The following is a description of a gene set: studied in species Homo sapiens Generation of the female gamete; specialised haploid cells produced by meiosis and along with a male gamete takes part in sexual reproduction. Human Gene Set: GOBP_FEMALE_GAMETE_GENERATION, and this is the list of marker genes: MEIOB, PAQR8, EDNRA, CCNB2, LSM14B (NCBI Gene Id 51153), NANOS1, ZFY, SPIRE1, M1AP, PGR (NCBI Gene Id 5241), PAQR7, BRCA2, LEP, NCAPH, HROB, ADAMTS1, PLK1, KASH5, MAJIN, SPO11, RPS6KA2, AMH, HSF2BP, RBM46, ETV6, SKA2, YTHDF2, FMN2, MLH1, LGR5, GAS2, CCNB1, YTHDC2, WASHC5, KAT8, YBX2, DCAF13, BMP15, SHB, AURKA, MEIKIN, TDRD5, KMT2D, FOXL2, PTEN, TRIP13 (NCBI Gene Id 9319), SOHLH1, REC114, PARN, GDF9, METTL3, IGF1, NANOS3, SKA1, IMMP2L, PPP2R1A, HORMAD1, NPPC, DDX20 (NCBI Gene Id 51452), MARF1, FBXO5 (NCBI Gene Id 26271), NDC80, FIGLA, INHBB, ERCC1, ZP3, DMRT1, GPR149, ORC4, SKA3, SPDYA, FSHR, PDE3A, C14orf39, NPM2, ZAR1L, TRIM75, ZMIZ1, BNC1, BCL2, MSH4, WDR77, MCMDC2, BCAS2, AKT1, SPIRE2, SOHLH2, ZGLP1, TERB2, MMP19, WNT4, IHO1, CGB7, NANOS2, INHBA, PTX3, SIRT1, SOS1, MMP2, EREG, MASTL, HSF1, MCM8, DMC1, PLD6, PTN, TDRD1, NOBOX, H3-3B, MEI4, TOB2, TOP2A, NOS3, SYCP2, MOS, DAZL, HPGD (15-hydroxyprostaglandin dehydrogenase), CGB3, PAQR5, TUT7, FUT6, CDC25B, MLH3, ATM, MDK, TUBB8, TDRD7, EHMT2, MCM9, ZAR1, TUT4, DDB1, RAB24, TNFAIP6, TDRKH, HEXB, STRA8, BMPR1B, TDRD6 (tudor domain containing 6), FSHB, UBB, ANG (NCBI Gene Id 283), SEPTIN1, YTHDC1, PANX1, MEIOC, EDN1, PRDM9, USP9X (NCBI Gene Id 8239), TAF4B, PIWIL2, NRIP1, IHH, FOSL1, TTK, FOXO3, SEBOX, CTNNB1, MEIOSIN (NCBI Gene Id 388553), ZNF830, BCL2L10, RXFP2, REC8, SIRT2, NCAPH2, WEE2, H3-3A, BRME1, DIAPH2, AFP, ASPM, SRC, NPR2, OOSP2